Given this list of marker genes FUT9, FUT11, FUT10, FUT6, FUT8, here is a description of the gene set: Human Gene Set: GOBP_N_GLYCAN_FUCOSYLATION species: Homo sapiens The process of transferring a fucosyl group to an N-glycan. An N-glycan is the carbohydrate portion of an N-glycoprotein when attached to a nitrogen from asparagine or arginine side-chains.